Given this list of marker genes PALLD, ALDH3B1, ALDH1A1, STX11, ACTA2, SEC31A, SNRPN, MTMR3, RHOBTB1, ITGB3BP, UGT2B7 (NCBI Gene Id 7364), PJA2, MPPE1, here is a description of the gene set: Human Gene Set: ABDULRAHMAN_KIDNEY_CANCER_VHL_DN von Hippel-Lindau (VHL) disease is a dominantly inherited family cancer syndrome characterized by the development of retinal and central nervous system haemangioblastomas, renal cell carcinoma (RCC) and phaeochromocytoma. Specific germline VHL mutations may predispose to haemangioblastomas, RCC and phaeochromocytoma to a varying extent. Although dysregulation of the hypoxia-inducible transcription factor-2 and JunB have been linked to the development of RCC and phaeochromocytoma, respectively, the precise basis for genotype-phenotype correlations in VHL disease have not been defined. To gain insights into the pathogenesis of RCC in VHL disease we compared gene expression microarray profiles in a RCC cell line expressing a Type 1 or Type 2B mutant pVHL (RCC-associated) to those of a Type 2A or 2C mutant (not associated with RCC). We identified 19 differentially expressed novel VHL target genes linked to RCC development. Eight targets were studied in detail by quantitative real-time polymerase chain reaction (three downregulated and five upregulated by wild-type VHL) and for six genes the effect of VHL inactivation was mimicked by hypoxia (but hypoxic-induction of smooth muscle alpha-actin 2 was specific for a RCC cell line). The potential role of four RCC-associated VHL target genes was assessed in vitro. NB thymosin beta (TMSNB) and proteinase-activated receptor 2 (PAR2) (both downregulated by wt pVHL) increased cell growth and motility in a RCC cell line, but aldehyde dehydrogenase (ALDH)1 and ALDH7 had no effect. These findings implicate TMSNB and PAR2 candidate oncogenes in the pathogenesis of VHL-associated RCC. species: Homo sapiens from publication Abdulrahman M, Maina EN, Morris MR, Zatyka M, Raval RR, Banks RE, Wiesener MS, Richards FM, Johnson CM, Latif F, Maher ER (PMID 17001320) Genes down-regulated in the RCC4 cells (renal cell carcinoma, RCC) expressing VHL mutants Type 1 and 2B (associated with RCC) but not those of Type 2A and 2C (not associated with RCC).